The following is a description of a gene set: species: Homo sapiens Human Gene Set: ZNF486_TARGET_GENES Genes containing one or more binding sites for (ZNF486) in their promoter regions (TSS -1000,+100 bp) as identified by GTRD version 20.06 ChIP-seq harmonization. from publication Yevshin I, Sharipov R, Kolmykov S, Kondrakhin Y, Kolpakov F (PMID 30445619), and this is the list of marker genes: ZNF536, ULK2, PLPP5, RN7SL322P, FA2H (fatty acid 2-hydroxylase), LINC02436, HERC1, ZNF410, LINC02159, CD209, NCAPGP1, SRGAP1 (NCBI Gene Id 57522), CHRNA3, PALM, CDKL5, FAM170B-AS1, DNAI3, GSTO1, SHC1P1, CRYM, CKB, PLLP, ODF2L, KLHL26, IL23R, COPA, TOP3B, MIR4715, EIF2S2P6, HEMGN, CCDC81, ARMC10, USP54, LINC02104, SLC24A5, STK10, MIR1252, RN7SL587P, CNOT4, SMPD4P1, RNU5A-5P (NCBI Gene Id 100873835), CHURC1-FNTB, PES1P2, APOBEC3B, PTP4A1, RBFADN, PPP4R1, MUC20-OT1, RBPMS, DLX6, DHX30, TRPV1, TPTE2P2, RNU6-1106P, KRT224P, KRT8P11, TRBV21OR9-2, RNU6-1059P (NCBI Gene Id 106480031), SINHCAFP2, SLC25A24, CDH10, ABCA9-AS1, STAG3L5P-PVRIG2P-PILRB, RN7SL473P, ZNF101P1, RABEP2 (rabaptin, RAB GTPase binding effector protein 2), NUP160, CEP164, RPL21P30, FRYL, OLFM3, ABCA8, SDHAP4, AAK1, RPS23P10, GUCY2C, HNRNPA3P3, LYPD9P, SCPEP1, TRBV21-1, RPS16P5, RNU6-1009P, RPA2P2, GOSR2, PIP4P2, CHURC1, PAPLN-AS1, HDAC1P2, RN7SKP27, HNRNPA1P24, RNU6-163P (NCBI Gene Id 106479638), OR7E104P, ARL5A, ACSM3, TXK, LINC01981, SLC22A15, PLAGL1, HMGN2P34 (high mobility group nucleosomal binding domain 2 pseudogene 34), DMGDH, SSBL2P, HDAC2-AS2, CPD, ST7, RN7SL802P, TOGARAM1, MYO1C, PPIAP33, DNAJC13, SLC3A1, PPIAP46, POLI, IL2RB, NEO1, MAMDC2-AS1, TENM3, FAM136A, DDX11L17, MTND1P34, ATP5PBP7, TPRX1, SPICP5, MIR99AHG, MIR3117, SNRNP27, RNA5SP399 (RNA, 5S ribosomal pseudogene 399), BRCA1, SNHG14, SEL1L3, MIR4773-2 (microRNA 4773-2), SNX29P2, GULP1, MTIF2P1, KMT2A, LINC01068, RIC1, KCNIP4, RPS26P56, DCTN4, ERBB4, TRIAP1P1, VN1R7P, LINC00868, PURPL, FADS2, ARL15, ADIPOR1, CDYL, NDEL1, EGR4, TRPC6P10, BTBD1, PCMTD1P3, CALM1P1, NRN1L, LRP12, CTNNA2, CCAR1, TPT1P15, TMC1, RFC1, ETF1P2, MIR7843, FAM216B, LNCRNA-IUR, ERCC6L2, MKX (NCBI Gene Id 283078), PRKAG2, STK31 (serine/threonine kinase 31), ST13P2, OR7E101P, CDC42EP3-AS1, RAB3GAP1, TUBGCP3, NCOA2, CNDP1, PLSCR5, CDH26, LIPM, MIR764, CYP4Z1, STK36, NECTIN1, RNA5SP117, RNU6-1323P, MTHFD2L, ACBD6, SPICP1, TRGV2, SLC13A3, CLASP2, SPOCK1, GSTA4, UBR5, LTBP4, RNU6-944P, CRX, MTCO3P44, RPL32P28, NRCAM, PRSS58, RNU6-232P, RPS3AP51, SLC36A4, TUBAP7, BAAT, ZCCHC4, MIR1277, LINC02050, RPS2P25, DISP1, ZNF567, TREML5P, MAP3K7CL, OR2A15P, CST7, DYTN, DNM1P38, HPSE, SSR1, SPOCD1, WEE2, LINC02953, CMKLR1, RN7SKP112, PSMD11, SNX29P1, ADAM18, PTPN2, ST13P14, TEC, GNG4, FBLN7, RN7SL392P, RPL12P21, JCHAIN, PTPRK, HSD3BP1, HTATSF1P2, IGLV1-62, SAT1, SMARCA1, LDHD, TLK1, BTRC, SDCBP, ZNRF1, HPAT5, DAD1, ZNF609, RNA5SP261, CMTM7, METAP1, ANO3, RN7SKP219, AKR1C7P, ITGAL, BRD7P7, PFDN4, LINC01722, RN7SKP59, DCUN1D2-AS, CDK14, HAUS8P1, FBXW8, RNA5SP232, C18orf21P1, IFNA2, SEM1, KRT18P68, PTPRD, RNU2-31P, ZNF780A, FHL2, FAM81B, RNU6-1310P, LINC00869, DNAJB6P1, HLA-DPB1, ZSCAN31, STAG3L5P, SPINK9, RABGAP1L, ISCA1P2, ENSG00000232234, CYP4F3, BEND7-DT, GTF2IP22, RNU7-148P, INSR, PHGDH, RNU6-567P, RFX3, CALCRL, ASMTL, GGTA1, ARL2BPP1, RNU1-52P, OR4A10P, RNU6-33P, RNA5SP157 (NCBI Gene Id 100873423), SNX12, NUDCD1